Given this list of marker genes H2AC16, NUP43, H4C13, H3C8, TUBAL3, VPS4A, H3C10, H2BC13, DYNC1I2, NUP58, NDC1, H4C4, TUBA4A, H2AC1, CHMP2A, TBL1XR1, HDAC3, NUP85, CHMP4C, TUBB4B, POM121, H4C2, TUBA3C, NCOR1, EED, TUBB3, H3C15, DYNLL1, H2BC7, EGFR, H2BC4, VPS37D, TUBB2A (tubulin beta 2A class IIa), MVB12A, DAXX, H2AC6, H3C4, H2BC18, TUBA3E, NUP160, HNRNPK, H2BC8, H4C6, CHMP1A, VPS28, H3C1, NUP54, TUBA8, NUP62, NFKB1, H3C3, RBBP7, NUP42, VPS37A, TPR, CHMP2B, DYNC1LI2, EZH2, H2AC25, SEH1L, H2AC13, H4C3, NUP107, VPS37B, NUP98, TUBB8B (tubulin beta 8B), PML, H4C9, H2AC20, H3C13, MVB12B, H4C8, CHMP4B, H2AC21, NUP188, DYNC1I1, NUP155, H2BC11, NUP205, NUP133, GPS2, H3C2, H2AC11, DYNLL2, H2BC14, CHMP6 (charged multivesicular body protein 6), VPS36, H2AC18, H2BC17, TUBA1C, TUBA1A, RAE1, TUBB4A, DYNC1LI1, H2BC12, H4C11, AAAS, TRIM28, TUBB1, SEC13 (NCBI Gene Id 6396), TBL1X, RANBP2, RBBP4, TUBA3D (NCBI Gene Id 150778), H2BC21, H4C12, H3C12, CHMP3, NUP50, H2BC15, CEBPD, H2BC1, NUP214, ELK1, TUBB8, H2BC10, H2AC15, NUP37, NUP153, CHMP4A, TSG101, H2AC12, H3C6, SUZ12, CREB1, H2AC17, H2AC19, POM121C, H4C16, NUP35, CBX1, NUP210, NUP88, H3C14, H3C7, TUBB2B, CHMP7, TUBB6, NUP93, H4C15, TUBA4B, DYNC1H1, H3C11, H2AC7, H2BC9, SNF8, VPS37C, H2BC26, H4C5, ITGB1, UBAP1, H2BC6, H2BC5, NCOR2, H2AC14, H4C14, TUBA1B, H2AC4, VPS25, H2BC3, H2AC8, H4C1, here is a description of the gene set: Human Gene Set: REACTOME_HCMV_INFECTION studied in species Homo sapiens HCMV Infection